Given this list of marker genes SUB1, SMC5, FEM1B, HSP90AB1 (heat shock protein 90 alpha family class B member 1), LSM4, TPT1, FTL, CTCF, EML5, SCAMP3, POLR3K, AKIP1, THBS3, PSMB8, EIF4H, RPL34, SCAND1, EXOSC9, BHLHE23, TUBA1B, TOPBP1, GLUD1, NUDCD2, FBXO43, HSPA8, RPS26, PBX1 (NCBI Gene Id 5087), RPL27A, RPL38, DDX5, RPS7, NNMT, MSH2, MRPL43, TNFAIP6, KXD1, PHF20L1, CNOT1, SLC8A3, RPL23, ERCC5, PPIA, RPS23, SLFN12L, RPS10, RPL19, TRIM37, GDF5, ATP5F1A, EEF2, RPS15A, RPL27, ILDR1, SLC25A6, PAG1, SNRK, HMGXB4, APOOL (NCBI Gene Id 139322), RPLP1, RPL7, TOR1AIP1, ZPBP, PCMT1, PDCD1, ATP5MC3, UQCRQ, RPS4X, WDR1, PRPSAP2, RPLP0, RAP1B, RPL9, TRAF2, B2M, ASF1B, FSCN3, RPS6KB1, NEFH, RPL18, TTC39B, DEK, UQCR11, RPL5 (NCBI Gene Id 90045), ABI1, NME2, SEC31A, WDR48 (NCBI Gene Id 57599), OXCT1, PCNA, DMD, APLP2, REG3A, IRF1, KIF4A, MOS, TERF2IP, CCN2, ZNF287, SYNJ2BP, C14orf180, RPS9, ZNF281, FOXQ1, RPS19, TUBGCP4, MRPS15, RPL12 (NCBI Gene Id 90679), SRGN, CYRIB, DNAJC9, COX4I1, RPL10, RNF187, RPS6, CHCHD2, RPL24, CCDC43, INCENP, PEX5L, CFP, RPS25, FUT9, RPS16, RAD23A, RIPPLY3, PRKAR1A, SAA4, MCM6, RAPSN, COX6C, KCNA3, RPL37 (NCBI Gene Id 6167), RAB6B, ASB16, SRPK3, NFATC4, MT1E, SPG21, RPS3, PCLAF, PPP1CA, CENPM, RPS14, SYCP1, MCM7, KCNK4, PLAAT3, TRIM26, PCBP1, IFIT2, ACTG1, RPS2, CHRNA5, HMGB1, RPS5, EIF4A1, PTPN21, TSG101, ACTB, MC2R, SLC25A3, RPS29, CYTIP, RPS3A, NUCKS1, RPL11, RPL6, SDHC, BMF, EIF3A, LTBP4 (latent transforming growth factor beta binding protein 4), SMARCAL1, EEF1G, ZC3H15, ATP5ME (NCBI Gene Id 521), NELFCD, RPL22, ZBTB48, UBC, FBH1, NLGN1, RPS18 (ribosomal protein S18), USP4, PRKD1, ST6GALNAC1, RPS21, ATG4D, YBX3, RPL7A, CAP1, CCN5 (cellular communication network factor 5), RPL3 (ribosomal protein L3), SNIP1, RPL39, KCNN2, PAPOLG, EP400 (NCBI Gene Id 84442), SYNE4, ZFYVE26 (NCBI Gene Id 338378), PRG2, here is a description of the gene set: from publication Knell J, Best JA, Lind NA, Yang E, D'Cruz LM, Goldrath AW (PMID 23325888) CD8+ T cells play a crucial role in the clearance of intracellular pathogens through the generation of cytotoxic effector cells that eliminate infected cells and long-lived memory cells that provide enhanced protection against reinfection. We have previously shown that the inhibitor of E protein transcription factors, Id2, is necessary for accumulation of effector and memory CD8+ T cells during infection. Here we show that CD8+ T cells lacking Id2 did not generate a robust terminally-differentiated KLRG1hi effector population, but displayed a cell-surface phenotype and cytokine profile consistent with memory precursors, raising the question as to whether loss of Id2 impairs the differentiation and/or survival of effector-memory cells. We found that deletion of Bim rescued Id2-deficient CD8+ cell survival during infection. However, the dramatic reduction in KLRG1hi cells caused by loss of Id2 remained in the absence of Bim, such that Id2/Bim double-deficient cells form an exclusively KLRG1loCD127hi memory precursor population. Thus we describe a role for Id2 in both the survival and differentation of normal CD8+ effector and memory populations. Human Gene Set: GSE41978_KLRG1_HIGH_VS_LOW_EFFECTOR_CD8_TCELL_DN Genes down-regulated in CD8 T effector cells during infection: KLRG1 high versus KLRG1 low. species: Homo sapiens